The following is a description of a gene set: studied in species Homo sapiens Human Gene Set: GOMF_INOSITOL_PHOSPHATE_KINASE_ACTIVITY Catalysis of the reaction: inositol phosphate + ATP = inositol phosphate + ADP., and this is the list of marker genes: IP6K3, ITPKB, IP6K1, IPPK, IPMK, ITPKA, ITPKC, IP6K2, ITPK1 (inositol-tetrakisphosphate 1-kinase), PPIP5K1 (diphosphoinositol pentakisphosphate kinase 1), PPIP5K2